The following is a description of a gene set: Human Gene Set: HP_ABNORMAL_RETINAL_VASCULAR_MORPHOLOGY A structural abnormality of retinal vasculature. species: Homo sapiens Abnormal retinal vascular morphology, and this is the list of marker genes: TMEM270, SSBP1, LAMB2, GGCX, COL4A1, RAX2, ANTXR1, ENPP1, KIZ, RREB1, DRAM2, IKBKG, HIRA, TTC8, MT-ND2, ASAH1, GTF2IRD2, RET, NUS1, CRX, SEMA4A, METTL27, DLK1, ZNF408 (zinc finger protein 408), GP1BB, RP1 (NCBI Gene Id 6101), USP45, DGCR2, RIMS1, CNGB1, FKBP6 (FKBP prolyl isomerase family member 6 (inactive)), ABCC6, TUB, IFT140, NCF1, MT-CO1, PDE6G, ARVCF, GUCY2D, SLC7A14, CTC1, ARL3, ETHE1, AHI1, G6PC1, BBS2, CCM2, PROM1, DHX38, MT-ND6, PDE6A, OPN1MW, RDH5, CENPF, AGBL5, FGF12, CA4, UFD1, GPIHBP1, ACVRL1, MT-ND5, RDH12, CACNA1F (NCBI Gene Id 778), WT1, EYS, HGSNAT, PRPH2, SMCHD1, PAX6, TBL2, ABCA4, FZD4 (NCBI Gene Id 8322), LPL, VHL, CLCC1, CDHR1, RPE65, SMAD4, FAM161A (NCBI Gene Id 84140), RPGR, CYP27A1, HBB, NEU1, MT-CYB, BBS1, ARL2BP, FUCA1, CFAP410, CLRN1, SCAPER, GTF2I (general transcription factor IIi), COMT, KIF1B, ADA2, RP9, HK1, ERCC4, F12, MAX, TTLL5, KIAA1549, GM2A, CRB1, CHM, RHO, APOE, EFEMP1, DLST, CERKL, NDP, GTF2IRD1, IMPG1 (NCBI Gene Id 6673), GUCA1A, GNAQ, YME1L1, MT-ATP6, CNNM4, IFT88, FLVCR1, IDH3A, DNAJC30, SLC6A6, FSCN2, RAB28, SLC24A1, TBX1 (NCBI Gene Id 7413), PDCD10, GNAT2, FRG1, HLA-A, DUX4L1, PDE6C, GDF2, STN1, CTNNB1, MT-CO3, MERTK, LRAT, ENG, PIK3CA, HEXB, CCDC28B, NDUFS2, KRIT1, RDH11, IMPDH1, PDE6H, JMJD1C, IGFBP7, TOPORS, CFAP418, UNC119, DUX4, SERPINC1, LRP5, POC1B, RLBP1, CNGB3, TULP1, PRPF4, RP1L1, PRPF8, SMPD1, EPAS1, PRPF6, PITPNM3, GUCA1B, DNMT3B, ESAM, PCNA, PRCD, NOD2, ROM1, WDR19, RTL1, MLXIPL, PRPF31, SPATA7, IFT43, MEG3, MT-ND4, SETD2, SDHB, CACNA2D4, RFC2, CTSA, AHR, PCARE, PRPF3, NR2E3, LIMK1, CNGA1, SLC37A4, KLHL7, MDH2, IDH3B, APOC2, USH2A, BUD23, ARHGEF18, CLIP2, ARL6, DNMT3A, TLCD3B, CC2D2A, MYOC, FH, SNRNP200, IVNS1ABP, RTTN, RBP3, ALMS1, CAPN5, IMPG2, SDHA, AIPL1, SLC25A11, HARS1, POMGNT1, TREX1, ESS2, DARS1, SDHD, HSD11B2, ELN, STX1A, NRL, BEST1, OFD1, CYP1B1, LOXL1, MT-ND1, BBS5, NEK2, OPN1LW, TRNT1, NEK1, GLB1, MVK, RPGRIP1, DGCR6, LCK, MAK, PDE6B, COL18A1, DGCR8, BBS9, DHDDS, MT-ND4L, PSAP, CNGA3, REEP6, ARV1, LRRC32, VPS37D, BAZ1B, TMEM127, RGR, NMNAT1, SELENOI, ZNF513, SDHAF2, HEXA (NCBI Gene Id 3073), ADAM9, EIF4H, GALC, MYD88, SAG, CLCNKB, TSPAN12, MKS1, NF1, SEC24C (NCBI Gene Id 9632), ATF6, IFT172, RP2, CCND1, SDHC, LCA5